Given this list of marker genes SLC26A2, WNT5A, SMO, WNT7A, IHH, GLUL, PRKAR1A, KIF7, COL2A1, RAD21, FAM20C, BMPR1B, CRTAP, LIFR, DYNC2I2, TCTN3, OBSL1, LBR, KIAA0586, NBAS, DDR2, CILK1, POLE, HHAT, EVC, DYNC2I1, WDR35 (WD repeat domain 35), CUL7, FGFR2, LRP4, SMC3, TRPV4, DYNC2LI1, INPPL1, COL11A1, CCN2, PUF60, IFT80, FZD2, ACTB, ANTXR2, CCDC8, CDKN1C, WDR19, DVL1 (dishevelled segment polarity protein 1), IDH1, DDRGK1, RNU4ATAC, DHCR7 (NCBI Gene Id 6589), PCNT, GLI1, SMC1A, PDE4D, DVL3, ACAN, HDAC8, RMRP, MATN3 (NCBI Gene Id 4148), SERPINH1, BRD4, ALPL, IFT81, IDH2, TTC21B, CEP120, GDF5, DPYD, CD96, EVC2, HYLS1 (NCBI Gene Id 50957), IFT172, KIAA0753, IFT43, MMP9, PHGDH, TRIP11, NIPBL, TAF6, B3GLCT, SLC35D1, SHOX, PRKACA, HSPG2, PTH1R, CSGALNACT1, GPC6, PAM16, PRKACB, APC (NCBI Gene Id 324), FGFR3, DHCR24, COL11A2, DYNC2H1, FLNB, IFT140, DONSON, here is a description of the gene set: studied in species Homo sapiens Micromelia The presence of abnormally small extremities. Human Gene Set: HP_MICROMELIA